Given this list of marker genes OTX2, MT-CYB, NSD2, KLHL3, MIR145, EPB41L1, REV1, MT-ATP8, ASB13 (ankyrin repeat and SOCS box containing 13), SOX12, TECR, NDUFS8, AHSA2P, COMMD3, SCARB1, TNFAIP8, LRRFIP2, BCAT2, BSG, ATP6V1A, ADPGK (NCBI Gene Id 83440), CDK5RAP3, SKIC3, C1orf21, FNIP1, WDFY1, NDUFA1, SLC23A2, FGF13, P3H2, CNTNAP3, PNISR (PNN interacting serine and arginine rich protein), TTC14, LINC00115, QTRT1, RIDA, MYL6, HOOK1, PLTP, GRSF1, ECHDC2, EYA2, CLTC, CKB, NDUFB1, TIA1, SAMD4A, ATP5PD, SNX13, DAPK2, KIAA1217, CSTF3, TNS3 (NCBI Gene Id 64759), ACACB, APBB3 (NCBI Gene Id 10307), TMEM38A, PDE4DIP, PPFIBP2, PFKP, GPHN (gephyrin), LSR, FLNA, NECAB2, MSI2, DSP-AS1, PLA2G15, CHD4, LINC01023, EPB41L3, PPM1K, ABCA4, PTPRG, CRELD1, DPP7, NDUFA2, FNBP4, PRPSAP1, ITFG1, NUMA1, CGGBP1, VCL, RGS11, ATF7IP2, GOLGA8A, DNAJC3-DT, LENG8, COX6C, RUFY3, MRPS28, ZSCAN16-AS1, COLGALT2, MT-ND1, ISLR (immunoglobulin superfamily containing leucine rich repeat), PCDH7, PDHA1, HIF3A, CCBE1, DUT, TSPAN9, KHDC4, IQCA1, CDH6 (NCBI Gene Id 1004), ITGAV, ZNF91, CTSK, SPARCL1, DMKN, ZC3H11A, MUC20, MFAP3L, TOB1, ACSS1, ATP5MJ, CYP4V2, PDLIM3 (PDZ and LIM domain 3), AGA, KTN1, MARS1, LONRF2, NBPF10, RBM24, AKT1, CES4A, FAM13A, COL4A3, TRIM33, CAPN7, FSTL1, DHPS, here is a description of the gene set: Occular cell types curated from Gautam and Hamashima et al. Multi-species single-cell transcriptomic analysis of ocular compartment regulons studied in species Homo sapiens Human Gene Set: GAUTAM_EYE_IRIS_CILIARY_BODY_PIGMENTED_CILIARY_BODY_CELLS from publication Gautam P, Hamashima K, Chen Y, Zeng Y, Makovoz B, Parikh BH, Lee HY, Lau KA, Su X, Wong RCB, Chan WK, Li H, Blenkinsop TA, Loh YH (PMID 34584087)